Given this list of marker genes HNRNPA1P30, FNTAP2, PRUNE1P1, RPL34P27, RN7SL741P, PARP4P2, GTF2IP3, LINC00463, RNU4-9P, ATP12A, TEX26-AS1 (NCBI Gene Id 100507064), HMGA1P6, USP12, PSPC1P1, LINC00427, GJB6, RNU6-58P, ST6GALNAC4P1, RPL23AP69, ENSG00000243008, ENSG00000277020, CDX2, PARP4, PRDX2P1, ENSG00000305468, CHCHD2P8, RPS21P8, URAD, KATNBL1P1, RBM22P2, ANKRD26P3, ENSG00000289125, SLC25A15P2, LINC00544, BASP1P1, MFAP1P1 (microfibril associated protein 1 pseudogene 1), USP24P1, RNA5SP25, MRPS31P2, SACS, USP12-AS1, SPATA13-AS1, AMER2, LINC00540, MPHOSPH8, GJA3, RNU6-64P, C1QTNF9, IL17D, CCNQP3, RPS3AP44, SLC35E1P1 (NCBI Gene Id 731344), RPL7AP73, ATP8A2P3, ENSG00000309412, LINC00572, RPS12P23, HMGB1, SPATA13, B3GLCT, LINC00412, GPR12, SGCG, DDX39AP1, ZMYM2, MEDAG, ANKRD20A10P, RNU6-70P, MIR2276, RN7SL766P, SHISA2, PAN3-AS1, CENPIP1 (centromere protein I pseudogene 1), ZDHHC20-IT1, LINC00365, EEF1A1P3, LINC00367, LINC00398, ALOX5AP, RANP8, THAP12P6, LINC01079, LINC00362, FGF9, IFT88, GJB2, TPTE2P6, CNOT4P1, GSX1 (NCBI Gene Id 219409), LATS2-AS1 (LATS2 antisense RNA 1), NUS1P3, PAN3, EIF4A1P7, RNF17, USPL1 (ubiquitin specific peptidase like 1), UBE2L5, LINC00556, RPLP1P13, FLT3, SMPD4P2, FTH1P7, TIMM8BP1 (translocase of inner mitochondrial membrane 8B pseudogene 1), LINC00297, ANKRD26P4, SACS-AS1, KATNAL1, HSPH1, LINC00424, LINC00385, MRPL3P1, GTF3A, RPL26P34, LINC00539, MTIF3, MICU2, TPTE2P1 (NCBI Gene Id 651239, TPTE2 pseudogene 1), RN7SL166P (NCBI Gene Id 106479282), ZMYM5, PDX1, RNY1P1, ENSG00000290911, SNORA27, RPL21, MTND3P1, MIPEPP3, ANKRD20A19P, SLC7A1, RNU6-73P, H2BP6, IRX1P1, LINC00384, PHF2P2, GOLM2P1, TEX26, POM121L13P, MTUS2, LATS2, LINC00543, RNU6-63P, ESRRAP2, LINC01046, UBL3 (ubiquitin like 3), LSP1P1, LINC00566, SLC25A15P3, RNF6, CYCSP32, ENSG00000293265, TNFRSF19, SAP18, ENSG00000287861, PCOTH, RNU6-53P, PLUT, C1QTNF9B (NCBI Gene Id 387911), ZDHHC20, ELOBP1, TUBA3C, MTCO3P2, LINC01072, KRR1P1, RPSAP54, LINC00327, NUP58, CENPJ, IPPKP1, CYP51A1P2, ATP5F1EP2, POLR1D, RNU6-82P, PPIAP27, RNY1P7, PSPC1P2, GRK6P1, MTUS2-AS1, LINC00442, GAPDHP52, ENSG00000238185, CYCSP33, POMP, ENSG00000289861, CRYL1 (crystallin lambda 1), TATDN2P3, ENSG00000296459, LINC01066, LNX2, RPS7P10, MIPEP, WASF3, MIR4499, PTPN2P2, RPS20P32, SKA3, FGFR1OP2P1, LINC00421, RNA5SP24, WASF3-AS1, RN7SL272P, RNU6-59P, RASL11A, MRPL57, ATP8A2, WDR95P, EEF1AKMT1, SNORD102, LINC00408, XPO4, PPIAP28, LINC01053, ESRRAP1, RNU6-78P, IPMKP1, ENSG00000308397, SLC46A3, PSPC1-AS2, RNU2-7P, CDK8, LINC01058, RFESDP1, IPO7P2, MTUS2-AS2, TPTE2, FLT1, PSPC1, ENSG00000287376, NUS1P2, SDAD1P4, ENSG00000262198, C1QTNF9-AS1, NME1P1, GAPDHP69, PABPC3, MTMR6, LINC00415, RNY3P4 (RNY3 pseudogene 4), RNY1P3, LINC00426, NPM1P4, TPTE2-AS1, LINC00352, LINC01076, LINC00621, here is a description of the gene set: species: Homo sapiens Human Gene Set: chr13q12